The following is a description of a gene set: Acanthocytosis Acanthocytosis is a type of poikilocytosis characterized by the presence of spikes on the cell surface. The cells have an irregular shape resembling many-pointed stars. Human Gene Set: HP_ACANTHOCYTOSIS species: Homo sapiens, and this is the list of marker genes: SAR1B, GATA1, KCNN4, VPS13A, CAD, TOR1A, PANK2, CYP4F22, XK (NCBI Gene Id 7504), SPTB, APOB, MTTP